Given this list of marker genes Ikzf2, Oaf, Pea15a, Snx12, Muc15, Ttc13, Chtf8, Oscar, AY761185, Zfand1, Zfp518a, Luc7l3, Pdgfra, Naa16, Gtpbp10, Nr5a2, Zfp644, Kera, Nol4, Zfp677, Brd9, here is a description of the gene set: from publication Chen Y, Wang X (PMID 31504780) studied in species Mus musculus Genes predicted to be targets of miRBase v22 microRNA mmu_miR_6962_5p in miRDB v6.0 with MirTarget v4 prediction scores > 80 (high confidence targets). Mouse Gene Set: MIR_6962_5P